The following is a description of a gene set: The process whose specific outcome is the progression of a keratinocyte over time, from its formation to the mature structure. Human Gene Set: GOBP_KERATINOCYTE_DEVELOPMENT species: Homo sapiens, and this is the list of marker genes: CDSN, KRT2, FLNB, BCL11B, SFN, IFT74, DNASE1L2, PALLD, PLEC, TFAP2C, EXPH5, FOSL2, KDF1 (keratinocyte differentiation factor 1), ABCA12